Given this list of marker genes Slc39a13, Slc30a5, Slc11a2, Slc30a10, Slc30a1, Slc30a9, Slc39a10, Slc39a12, Slc30a6, Slc30a2, Slc39a7, Slc39a8, Slc39a2 (solute carrier family 39 (zinc transporter), member 2), Slc39a1, Trpm7, Slc39a3, Slc30a3, Slc39a5, Slc39a14 (solute carrier family 39 (zinc transporter), member 14), Slc39a11, Slc39a4, Slc39a6, Slc30a4, Slc30a7, Slc39a9, Slc30a8, here is a description of the gene set: studied in species Mus musculus Enables the transfer of zinc (Zn) ions from one side of a membrane to the other. Mouse Gene Set: GOMF_ZINC_ION_TRANSMEMBRANE_TRANSPORTER_ACTIVITY